Given this list of marker genes Lck, Cd80, Pak3, Cd28, Grb2, Cdc42, Vav1, Fyn, here is a description of the gene set: species: Mus musculus Reactome Pathway: CD28 dependent Vav1 pathway part of: Co-stimulation by CD28 This event has been computationally inferred from an event that has been demonstrated in another species.<p>The inference is based on the homology mapping from PANTHER. Briefly, reactions for which all involved PhysicalEntities (in input, output and catalyst) have a mapped orthologue/paralogue (for complexes at least 75% of components must have a mapping) are inferred to the other species. electronically inferred by orthology from the curated human pathway